Given this list of marker genes SOX9, AHI1, HIPK1, STRA6, RPGRIP1L, NDP, ATF4, SOX1, FJX1, VEGFA, TENM3 (teneurin transmembrane protein 3, NCBI Gene Id 55996), SDK2, ZHX2, LARGE1, FZD5, RHO, IRX5, COL8A2, TDRD7, JAG1, BMP7, CITED2, PAX2, NRL, SKI, CRYAA, FOXF2, NF1, TSPAN12, VSX1, CABP4, GDF11, RDH13, EPHB1, MEIS1, MEGF11, PDE6C, NECTIN1, CDON, HCN1, SOX8, FRS2, BBS10, BCAR3, DSCAM (NCBI Gene Id 1826), MFSD2A, SAMD7, ABI2, BAX (BCL2 associated X, apoptosis regulator), RPGRIP1, ZEB1, FAT3, TWIST1, TFAP2B (transcription factor AP-2 beta), IHH, TH, SLC1A1, FOXE3, PROM1, SIX3, RBP4, WNT16, IFT172, PROX1, YY1, SOX12, WNT9A, WNT5A, MFN2, ARL6, SDK1, CRB2, EPHB2, ATP8A2, PTPRM, AQP1, LCTL, TTC8, PHACTR4, SOX11, DIO3, CRYGB, RORB, TSKU, PAX6 (paired box 6), TBX2, DLL1, FOXN4, PRDM1, SAMD11, GNAT2, PITX3, SOX4, CRB1, NOTCH2, WNT2, NTRK2, HIPK2, SP3, IFT122, KDR, CNTF, ADAMTS9 (ADAM metallopeptidase with thrombospondin type 1 motif 9), EPHA2, CTNNB1, PTF1A, KDM2B, CALB1 (calbindin 1), VSX2, COL8A1, C12orf57, MAN2A1, WNT2B, NOTCH1, STAT3, ALDH1A3, HIF1A, ROM1, NAGLU, RP1, HMGN1, TFAP2A, FAT1, SHROOM2, GNAT1, GLI3, THRB, AQP5, RS1, IMPG2, TBC1D20, BBS4, BMP4, LRP5, THY1, RING1, NECTIN3, USH1C, PITX2, LHX1, BAK1, here is a description of the gene set: studied in species Homo sapiens Human Gene Set: GOBP_CAMERA_TYPE_EYE_MORPHOGENESIS The process in which the anatomical structures of the eye are generated and organized. The camera-type eye is an organ of sight that receives light through an aperture and focuses it through a lens, projecting it on a photoreceptor field.